The following is a description of a gene set: studied in species Homo sapiens Human Gene Set: HP_APLASIA_HYPOPLASIA_OF_FINGERS Small/hypoplastic or absent/aplastic fingers. Aplasia/Hypoplasia of fingers, and this is the list of marker genes: BRF1, NEPRO, KIF21A, PLXND1, FANCG, FANCA, IGF1R, EIF4A3, PPOX (NCBI Gene Id 7440), TRIM8, REV3L, NFIX, RYR3 (ryanodine receptor 3), IFT52, FGFR2, ZMPSTE24, TUBB3, TRPM3, DLX5, RPS19, BRCA1, PIGF, PIGL, TBX3, PORCN, GRM7, VAC14, GJA8, ARHGAP31, GNB2, RPL11, CHD7 (chromodomain helicase DNA binding protein 7), RPL35, SCN1B, TRIO, DHODH, STAMBP, ASAH1, RPS27, SLC25A24, GRIN1, MEGF8, POU1F1, FGFRL1, CPLX1, TUBB2B, JAG1, HOXA13, LETM1, SOX11, PIGS, FANCE, BMPR1B, SIN3A, PRKG2, LBR, IFT122, BRIP1, LMNB2, PDE4D, EVC2, FLNB, TRPS1, RPS26, TBX5, BICRA, RPL35A, TP63, ARID2, LMNA, PIGG, DVL1, ERCC4, PIGN, HEATR3, NSD2, FANCD2, PALB2, MAP3K7, PCNT, ACP5, GGCX, LAMA5, FANCF, MBD5 (NCBI Gene Id 55777), PIGV (phosphatidylinositol glycan anchor biosynthesis class V), HMGA2, SEM1, DMXL2, ZBTB20, MTOR, RECQL4, IFT43 (NCBI Gene Id 112752), PNKP, OFD1, PKDCC, FANCM, NSUN2, POLA1, MAPK1, ARSL, PTH1R, PHF6, RAC1, TBL1XR1, PSMD12, PRMT7, KIF15, PGAP3, CHST3, BCR, DDR2, MAFB, CTBP1, KCNN3, ALOX12B (arachidonate 12-lipoxygenase, 12R type), NXN, DLL4, ERI1 (NCBI Gene Id 90459), BTRC, GPC3, LTBP2, ARID1A, IHH, SMARCA2, RPL5, ADAMTS17, EN1, GPX4, WNT10B (Wnt family member 10B), SLC25A22, CHRNA1, CDC42BPB, SLC32A1, KNSTRN, MAD2L2, COL2A1, ACAN, PIGA, GNPNAT1 (glucosamine-phosphate N-acetyltransferase 1), RB1, CDKN1C, PRKACA, PHOX2A, RPS15A, LIG4, SALL4, CEP152, SMARCE1, WNT5A, SMOC1, RPS7, PIGO, DLX6, SMARCC2, FZD2, PRKACB, RPS10, POR, TSR2, SLC26A2, BMP2, FGF10, ERF (NCBI Gene Id 2077), RBM8A, RPS20, PUM1 (pumilio RNA binding family member 1), CASK, KCNH1, MASP1, LMBR1, AP1G1, WNT7A, SON, TFAP2A, OBSL1, MYCN, RAI1, KCNJ8, HOXD13, BHLHA9, CUL7, RPL31, SMARCA4, LHX3, SRCAP, NELFA, MED12, WDR19, CCDC22, DOCK6, FANCB, MECOM, CTSK, RPL10, AIFM1, GLI1 (NCBI Gene Id 2735), BRD4, ZNF699, TBC1D24, CRIPT, RTL1, RAD21, HNRNPR, EDA, PTHLH, ROR2, POC1A, GNAO1, EDA2R, SLX4, GLI3, ZMIZ1, ALMS1, FLNA, CHST11, ABCA12, CBFB, GPC4 (glypican 4), COG4, FBN1 (NCBI Gene Id 7470), XRCC2, FBXW4, EVC, PLAG1, FANCI, SIK1, SHH, DYNC2LI1, SETBP1, KDM6A, FGFR3, RPL8, ACVR1, PGAP2, ALOXE3, UBE2T, NEUROD2, COX4I1, TCTN3, TAF6, BCOR (BCL6 corepressor), GDF5, NEK1, PIK3CD, COMP, DLK1, GATA1, SCN2A, NIN, NOTCH2, SVBP, ROBO1, EIF2AK3, COL25A1, ADAMTS10, PUF60 (poly(U) binding splicing factor 60), LRP4, ARID1B, SMAD4, FN1, INTU, SMARCB1, FTSJ1, ALG6, CHRND, KDM1A, RPL9, MCTP2, RMRP (RNA component of mitochondrial RNA processing endoribonuclease), PIGQ, CUL3, NSDHL, RPS17, HESX1, SMC1A, SMC3, KCNJ2, FANCC, GJA1, MGP (NCBI Gene Id 4256), RIPK4, RSPO2, RPL26, CRKL, SOX4, RPS29, TFAP2B, CNOT2, MIR17HG, IGF2, WDR35, MEG3, LHX4, PIK3C2A, RPS28, ZMYM2, FRAS1, ADA2, RAD51C, SMARCD1, RFWD3, CHN1, MEIS2, RUNX2, KMT2A, RAD51, KDM5C, PCYT1A, NIPBL, PIGB, ACTL6B, DONSON, PDGFRB, VPS35L, FGFR1, TRPV4, CREBBP, TUBA1A, ABCC9, SOX9, FGD1, NOG, PIGW, RPS6KA3, GMNN, APC, NOTCH1, EP300, ARX, MAPK8IP3, CHRNG, DPF2, PTCH1, SF3B4 (splicing factor 3b subunit 4), RPS24, CLCN7, IFT140 (intraflagellar transport 140, NCBI Gene Id 9742), GJA5, KMT2D, PIGY, HDAC8 (histone deacetylase 8), KCNA1, COL10A1, EOGT, PROP1, EPS15L1, RBBP8, DHCR7, FIG4, RBPJ, ATP6V1B2, CWC27, ASCC3, ASPH, IFT57, CANT1, GNAS, RNU4ATAC, TWIST1, IRX5, RPL15, BMP4, CDKL5, RPL27, PIGP, WIPI2, RPL18, BRCA2, FANCL, ESCO2